Given this list of marker genes ATXN3, HAX1, ARSI, SPG7, BEAN1, PRX, PLOD1, RFC1, SH3TC2, MPZ, MFN2, PMP2 (NCBI Gene Id 5375), KIF1A, VCP, ENSG00000288330, PRORP, CADM3, VAMP1, LMNB1, RNF170, MORC2, EGR2, GARS1, MAG, HARS1, FLRT1, XRCC1, SYNE1, ATXN8OS, UBAP1, TPP1, POLR3A, MTTP, ERLIN2, WDR48, FLVCR1, REEP2, SLC33A1, SPART, RTN2, IMPDH2, KLHL9, SLC25A15, PI4KA, HK1, GNB4, PLEKHG4, PNKP, DHTKD1, FGF14, PNPT1, SPTAN1, BSCL2, ATXN2, VPS13A, SPG11, KIF5A, POLR3B, SAR1B, GBA2, SACS, PRDM12, NAGLU, NEFL, DDHD1, GCH1 (GTP cyclohydrolase 1), JAG1, UCHL1, WASHC5 (WASH complex subunit 5), PEX10, LRSAM1, VPS37A, SPAST, CHCHD10, ATP1A1, MPV17, DARS2, PRKCG, NEFH, KPNA3, NR4A2, NDRG1, ZFYVE26, PDYN, FMR1 (fragile X messenger ribonucleoprotein 1), PDK3 (NCBI Gene Id 5165), CHP1, APTX, MTRFR, NIPA1, GDAP1 (ganglioside induced differentiation associated protein 1), B4GALNT1, KCNC3, FXN, ATXN1, TDP1, KCND3, ATP13A2, KLC2, SPTLC2, CPT1C, MT-TE, SLC12A6, POLG, CACNA1G, ERBB3, DCAF8, HSPD1 (NCBI Gene Id 56733), SPTBN2, XK, SCO2, SAMD9L, ATL1, AMPD2, ABCD1, PDXK, SORD, PEX6, SCP2, TWNK, REEP1, PMP22, CYP7B1, DHH, MT-ATP6, NGF, ALDH18A1, HINT1, SETX, here is a description of the gene set: Human Gene Set: HP_IMPAIRED_VIBRATORY_SENSATION Impaired vibratory sensation studied in species Homo sapiens A decrease in the ability to perceive vibration. Clinically, this is usually tested with a tuning fork which vibrates at 128 Hz and is applied to bony prominences such as the malleoli at the ankles or the metacarpal-phalangeal joints. There is a slow decay of vibration from the tuning fork. The degree of vibratory sense loss can be crudely estimated by counting the number of seconds that the examiner can perceive the vibration longer than the patient.